The following is a description of a gene set: Catalysis of the removal of a methyl group from one or more nucleosides within a DNA molecule. Mouse Gene Set: GOMF_DNA_DEMETHYLASE_ACTIVITY species: Mus musculus, and this is the list of marker genes: Alkbh3, Alkbh1, Alkbh4, Fto, Alkbh2